Given this list of marker genes SRSF10, CNOT7, ZMAT3, ZMYND11, PSPC1, PRPF40A, SLC39A14, OGT, UGDH, RASSF3, DOCK10, VAPA, MIB1, ATF7, DACT1, PSORS1C2, EXOC8, SNRPC, CAB39, DPY19L1, FBXO33, ZMYM2, GNAQ (G protein subunit alpha q), SSB, CCNA2, CHD4 (NCBI Gene Id 1108), ROBO1, BAHCC1, PTBP3, MBTD1, ASTN2, SMC3, SLC25A36, VTI1A, TRIM66, PARP12, RNF185, TTC28, SNAP47, ABHD17B, CDH13, PCBP2, RNF169, ZNF287, AEBP2, TEAD3, RFX3, IL1RAP, MEX3C, DDX3Y, RBM7, TIPARP (NCBI Gene Id 25976), TMEM33, ZC3H12C, PJA1, CDK17, HSD17B12, here is a description of the gene set: species: Homo sapiens Genes predicted to be targets of miRBase v22 microRNA hsa-miR-548ay-3p in miRDB v6.0 with MirTarget v4 prediction scores > 80 (high confidence targets). Human Gene Set: MIR548AY_3P from publication Chen Y, Wang X (PMID 31504780)